Given this list of marker genes Sdha, Ndufs6, Prpsap1, Ndufv1, Gucy1a1, Ndufb1, Shmt1, Rrm2, Adsl, Nppb, Nadk, Atp5me, Dhodh, Hprt1, Ndufv2, Ak2, Ndufa11, Ppat, Ndufa9, Adcy4, Ndufs8, mt-Nd4l, Ndufb3, Ampd2, Atp5f1e, G6pdx, Nppa, Uckl1, Rd3, Ndufs5, Gucy2g, Ampd1, Atpsckmt, Ndufs1 (NADH:ubiquinone oxidoreductase core subunit S1), Gucy1b1, Sphk2, Prps1, Dhfr, Oasl2, Letmd1, Entpd1, Papss2, Atp5mg, Sdhc, Nme5, Haao, Ndufs3, Gmps, Adcy9, Ndufa5, Ndufa10, Sdhb, Guca1a, Atp5f1d, mt-Nd5, Nmnat1, Ndufc1, Tbpl1, Atp6-ps, Dtymk, Lipa, Ndufb4, Adss1, Slc4a7, Atp5mc1, Cmpk1, Ndufa8, Hnf1a, Pid1, Mthfd1, Adcy8, Ndufc2, Atp5mc2, Bcl2l1, Adcy10, Uck1, Atp5mc3, Nmrk1, Nmnat2, Slc25a12, Paics, Gucy2d, Ppara, Slc25a13, Ndufa1, mt-Nd1, Nme3, Pfas, Ak8, Ada, Ndufb2, Nme7, Ndufb6, Eno1, Ndufa13, Ak9, Uck2, Pth2, Vcp, Guca1b, Rrm1, Slc25a51, Npr1, Dmac2l, Mthfd2l, Ak4, Ndufb8, Nudt2, Atp6v1a, Ak5, Aspdh, Qprt, Aprt, Ak1, Oas1a, Adcy5, Cda, Slc52a3, Atp5f1a, Adss2, Papss1, Dut, Tyms, Adcy7, Impdh1 (NCBI Gene Id 320849), Nme2, Stoml2, Ndufa3, Gart, Ndufb5, Ido1, mt-Nd2, Atp5po, Atp5pb, Uprt, Ndufb7, mt-Nd4, Slc52a2, Atp5f1b, Flad1, Ndufs4, Eno1b, Upp2, Prkn, Nmnat3, Prps2, Tgfb1, Ndufs2, mt-Atp8, Impdh2-ps, Tmsb4x, mt-Nd6, Adk, Ndufv3, Nampt, Gars1, Atp5mf, Afmid, Map2k1, Atp5pd, Idh2, Gucy2c, Impdh2, Ndufb11, Stat3, Umps, Gucy2e, Nme6, Gmpr, Uqcc3, Npr2, Ak6, Dnajc30, Dguok, Ampd3, Nos3, Ctps2, Myc, Trem2, Shmt2, Nme1, Ndufa12, Adora2b, Rrm2b, Guk1, Kars1, Atic, Nmrk2, Ndufs7, Atg5lrt, Ndufab1, Pnp2 (NCBI Gene Id 667034), Nme4, Antkmt, Ndufa7, Ndufb10, Kynu, Ak3, Adcy3, Ak7, Ldhd, Mapk1 (mitogen-activated protein kinase 1), Ndufa2, Ctps1, Dctd, Atp5f1c, Rfk, Gucy2f, Adcy1, Prps1l3, Prpsap2, Cmpk2, Fam3a, Adcy6, Kmo, Prps1l1, Cox11, Aldoa, Dck, Ido2, Pnp, Ndufb9, Adcy2, mt-Atp6, Nppc, Il4, Parp1, Naprt, Nadk2, Ldhc, Nadsyn1, Gmpr2, Cad, Ndufa6, mt-Nd3, Upp1, Atp5if1, Sdhd, Atp5pf, here is a description of the gene set: The chemical reactions and pathways resulting in the formation of nucleotides, any nucleoside that is esterified with (ortho)phosphate or an oligophosphate at any hydroxyl group on the glycose moiety; may be mono-, di- or triphosphate; this definition includes cyclic-nucleotides (nucleoside cyclic phosphates). Mouse Gene Set: GOBP_NUCLEOTIDE_BIOSYNTHETIC_PROCESS species: Mus musculus